Given this list of marker genes Fmo5, Fmo4 (flavin containing monooxygenase 4), Fmo1, Fmo2, Fmo3, here is a description of the gene set: Catalysis of the reaction: H+ + hypotaurine + NADPH + O2 = H2O + NADP+ + taurine. studied in species Mus musculus Mouse Gene Set: GOMF_HYPOTAURINE_MONOOXYGENASE_ACTIVITY